The following is a description of a gene set: Mouse Gene Set: GOBP_REGULATION_OF_MITOTIC_CENTROSOME_SEPARATION species: Mus musculus Any process that modulates the frequency, rate or extent of the separation of duplicated centrosome components at the beginning of mitosis., and this is the list of marker genes: Map9, Kif11, Nsfl1c, Ubxn2b, Cep85, Nek2, Ranbp1, Chek1